Given this list of marker genes JARID2, GOLIM4, GSR, SPP1, KLF5, CNP, TPR, PARG, SP110, ECE2, GRINA, TSC22D1, IL23A, ASB3, GJA4, SLC25A38, EGFR, C19orf12, CDH11, AATF, GRIK2, ATP6V1E1, TIMP1, C9orf72, GRK2, PARD3B (NCBI Gene Id 65063), METAP1, VSX1 (NCBI Gene Id 8198), GTF2E2, PLAC8, SERPINB7, SHOX2, STRA8, PTGR3, NAMPT, RBM8A, ZNG1B, PSMC4, CRYM, GSC, GTF2IRD2, OLR1 (NCBI Gene Id 4973), CD14, IFITM10, SERTAD1, PSENEN, UTP11, MMP14, PENK, FAM184B, SFTPA1, NOP58, TNFRSF1B, EXTL1, SYNPO2, AGFG1, MED21, N4BP1, DTNB, DDIT3, CPD, ITGA2B, ZNF189, HDAC1, CAB39L, PLEKHF2, PSMB9, RHOG, DUSP26, SLC6A4, CD47 (NCBI Gene Id 961), CCDC71L, SERPINE1, EIF2S1, GFRA4, GBP2, TSR1, IER5, DNER, ATXN7L1, C1QL3, SPTLC2, GPN2, KLK6, G3BP2 (G3BP stress granule assembly factor 2), SNX10, RNF126, EVA1A, PLK2, ILF3, MOB4, TCF21, KREMEN1, PDLIM4, IFT81, PPP2R2D, SAMSN1, HSD3B2, TBC1D13, RPE, CD82, GOLT1B, MTMR14, SOCS1, MST1R, ARID5B, ARID3B, CBLN1, KIF21B, MYORG, SENP6, ME1, PLA2G2A, NINJ1, PHC2, ZDHHC6, XRN2, ASB6, TMEM243, ZNF18, C11orf68, HTRA2, IGBP1, POLE4, PMPCB, SCRG1, POU2F2, NOLC1, NR5A2, CPEB1, HOOK2 (NCBI Gene Id 29911), FKBP1A, SLAMF1, MMP2, SLAMF6 (SLAM family member 6), COL22A1, CCL5, DNAJB11, TOR3A, PCNX1, SLFN13, PKP4, SLC26A8, SIRT2, IL15RA, SOX12, MACROH2A1, TAP1, CHIC2, M1AP, RNF114, EHBP1L1, CHST7, NR0B2, IFNAR2, CFAP184, TMEM30A, PSORS1C2 (psoriasis susceptibility 1 candidate 2), RBM43, CACYBP, PRPF38A, SLIRP, MPP3, SEC24D, SQSTM1, RAD23A, TBK1, REPS1, PMVK, GDE1, KARS1, PHLDB1, CHDH, CD200, PEF1, TUBA1B, CITED2, BLOC1S4, SCX, HSPB8, UBE2S, TTC1, SLC28A2, OAS2, RANBP1, HSP90AA1, EIF3D, BIRC3, ESD, RPS6KA2, TMA16, NECTIN2, MITD1, SLC27A1, RBM19, PFDN2, PWP2, NRBF2, C1orf52, here is a description of the gene set: Genes down-regulated in comparison of control dendritic cells (DC) at 12 h versus those stimulated with LPS (TLR4 agonist) at 12 h. from publication Amit I, Garber M, Chevrier N, Leite AP, Donner Y, Eisenhaure T, Guttman M, Grenier JK, Li W, Zuk O, Schubert LA, Birditt B, Shay T, Goren A, Zhang X, Smith Z, Deering R, McDonald RC, Cabili M, Bernstein BE, Rinn JL, Meissner A, Root DE, Hacohen N, Regev A (PMID 19729616) mouse primary BMDCs were stimulated with tlr ligands and gene expression changes were profiled on Affymetrix arrays Human Gene Set: GSE17721_CTRL_VS_LPS_12H_BMDC_DN species: Homo sapiens